The following is a description of a gene set: studied in species Homo sapiens from publication Chen Y, Wang X (PMID 31504780) Human Gene Set: MIR4640_3P Genes predicted to be targets of miRBase v22 microRNA hsa-miR-4640-3p in miRDB v6.0 with MirTarget v4 prediction scores > 80 (high confidence targets)., and this is the list of marker genes: FOXO4, MBD6, SGIP1, AAGAB, MITF (melanocyte inducing transcription factor), MGAT4A, DNAJC16, ZNF217, LRRIQ1, ZBTB34, CSMD1, PDCD4 (programmed cell death 4), PDE4B, EEF1AKMT3, PAGR1, SIMC1